The following is a description of a gene set: Genes down-regulated in liver tissue upon knockout of HNF1A. Heterozygous HNF1A mutations cause pancreatic-islet beta-cell dysfunction and monogenic diabetes (MODY3). Hnf1alpha is known to regulate numerous hepatic genes, yet knowledge of its function in pancreatic islets is more limited. We now show that Hnf1a deficiency in mice leads to highly tissue-specific changes in the expression of genes involved in key functions of both islets and liver. To gain insights into the mechanisms of tissue-specific Hnf1alpha regulation, we integrated expression studies of Hnf1a-deficient mice with identification of direct Hnf1alpha targets. We demonstrate that Hnf1alpha can bind in a tissue-selective manner to genes that are expressed only in liver or islets. We also show that Hnf1alpha is essential only for the transcription of a minor fraction of its direct-target genes. Even among genes that were expressed in both liver and islets, the subset of targets showing functional dependence on Hnf1alpha was highly tissue specific. This was partly explained by the compensatory occupancy by the paralog Hnf1beta at selected genes in Hnf1a-deficient liver. In keeping with these findings, the biological consequences of Hnf1a deficiency were markedly different in islets and liver. Notably, Hnf1a deficiency led to impaired large-T-antigen-induced growth and oncogenesis in beta cells yet enhanced proliferation in hepatocytes. Collectively, these findings show that Hnf1alpha governs broad, highly tissue-specific genetic programs in pancreatic islets and liver and reveal key consequences of Hnf1a deficiency relevant to the pathophysiology of monogenic diabetes. from publication Servitja JM, Pignatelli M, Maestro MA, Cardalda C, Boj SF, Lozano J, Blanco E, Lafuente A, McCarthy MI, Sumoy L, Guigó R, Ferrer J (PMID 19289501) species: Mus musculus Human Gene Set: SERVITJA_LIVER_HNF1A_TARGETS_DN, and this is the list of marker genes: PNPLA3, HES6, PRKD3, AFM, FTCD, BCO1, RDH16, FRK, ADH4, SERPINA9, DCT, IL13RA1, HSD17B2, ALDH1L1, ELOVL3, KYAT1, AASS, SLC3A1, IGFBP4 (insulin like growth factor binding protein 4), C5, LECT2, SCLY, SLCO2A1, ADGRF1, SCARA5, C9, CYP4V2, FMO5, PDGFC, CAPN10, FGF1, BDH2, TRAM1, CES3, PRODH2, HRG, C8B, SPSB4 (splA/ryanodine receptor domain and SOCS box containing 4), IGFALS, CYP7B1, CMAHP, EGFR, PPARD, CABYR, SLC22A25, SLC30A10, CFH, PLA1A, CLDN2, DPP4, APOM, ARHGAP26, SIGIRR (single Ig and TIR domain containing), ZKSCAN1, ALAS2, LY6E, SLC41A2, HSD3B2, NR0B2, C1R, F11, SLC23A1 (NCBI Gene Id 9963), MMD2, CPB2, FRAS1, PIGR, CFI, MAD1L1, ITIH1, NRBP2, EEF1A2, LIFR, MBL1P, CXCL9, CTSC, IL1R1, CHRNA4, POLR3K, SAA4, SLC16A10, EGR1, AKR1C4, IGF1, ONECUT1, FABP1, UGT3A2, CELA1, SLC17A3, CELSR1, CAMK1D, APCS, NR1H4, SERPINA1, HABP2, HOPX, PLG, P2RY13, BMAL1, EIF2S3, CA5A, CYP4F2, UBTF, LIN7A, CYP2J2, FGFR4, NOX4, HAO1, PAH, ADRA1B, SAA1, F13B, ESR1, SLC22A7, SYT1, PIP4K2B, ANG, IL1RAP, SLCO1B3, C6, FPGS, RASSF5, SERPING1, MCM10, CHKA, ROR1, MYCN, SLCO1A2, PKHD1, CLDN14, CLEC2D, IRGM, LOXL4, HSD11B1, SLC37A4, C8A, ERO1B, CCNF, RTP3, UGT2B4, SNTG2, HSD3B1, CDH1, PTGDS, ACP3, CADPS2, GBP2, SERPINA12, E2F8, CXCL13, DACH2, SOX6, DOCK8, UGT2A3, CRP, CYP2C19, CYP26A1, NIT2, PLA2G4A, PPP1R3C, DDC, TFF3, LCP1, SLC25A45